Given this list of marker genes ARPC1A, KDM1A, MDM4, FAM204A, TMEM68, COPS7A, USP22, NUP133, MDC1, PTRH2, CSNK1A1, CASP6, XRCC6, GNL2, ZFR, RGMB, TOR1B, CNKSR3 (CNKSR family member 3), MOGS, TESK1, KBTBD4, EXOC5, MOB1B, DDX19B, EFTUD2, GMPPB, VPS50, ADGRE5, SUCO, CYP4A11, ZNF644, C5orf34, CDK6, GNPTG, H2AX, PCYT2, DIABLO, GMDS, IFT140 (NCBI Gene Id 9742), YBX3, GPR89B, DPP7, MED13, MAD2L2, TRIR, RAB3GAP2, FLT3, MIGA1, RBPJ, PRKAR2A, BMPR2, SMIM30, PLBD2 (phospholipase B domain containing 2), EIF4G3, GLRX3, ZNF655, RAP1GDS1, CTDSPL2, ATG5, ZNF565, PDE4DIP, TRIT1 (NCBI Gene Id 54802), C10orf88, FTSJ3, LAMP1, IWS1, DNAJB11, TCF7L2, TLE4, STAU2, RPL13A, RCOR3 (REST corepressor 3), SPMAP1, ACTR10 (NCBI Gene Id 55860), HPGDS, NCOA3, ABI2, ERAP1, YIPF4, SLC39A2, BRMS1L (NCBI Gene Id 84312), RSPRY1, ROCK2, HDAC3, MRPL22, FPR2, PPIH, IFT57, IRAG2, ABCB6, LONRF3, HOOK2, RORA, TMEM70 (NCBI Gene Id 54968), GGNBP2, SMC2, PHTF2, RDH14, C5orf24, HDHD5, B4GALT1, CENPQ, CSGALNACT2, MRPS34, THAP4, SUV39H1, PECR, ZNF322, RAC1, EAF2, CEP135, DTWD2, RNASEH2A, MGA, ANXA7, SLC52A2, XPC, TAF1B, AAK1, CLPX, MANF, RPS25, CUL2, QTRT2, ASNSD1, WDR3, ACD, PLEKHA3, RCN2, PSMD4, BOP1, PHF23, HLA-DRB1, HECA, MAPK1IP1L, EMC2, MRPL38, KCTD10, FAM174A, PRXL2C (peroxiredoxin like 2C), C8orf76, GEMIN5, EMB, CREBRF, ARID4A, NKAPD1, FUCA1, FAM98A, LACTB, CXCR6, CDC27 (cell division cycle 27), UBE3D (NCBI Gene Id 90025), DDX24, GFM1, SPAG4, DNAJC6, BTBD19, FPGT, TMEM179B, ECI1, MARVELD2, EGR3, CIMIP6, SMIM7, PDLIM5, CXCL3, COX17, ATG2A, PTGES2, TRAPPC10, TXNDC5, SEC63, DALRD3, MED19 (mediator complex subunit 19), HOOK3, ELAPOR2, PARG, ORC3, JMJD6, IL1RN, SNX25, INTS11, PSPH, NIPSNAP3A, ELOC, ERG28 (ergosterol biosynthesis 28 homolog), CENPL, COQ7, APOE, PFN1, TTC5, CFAP69, TRAPPC8, QNG1, OXSR1, FGA, ZHX2, COPS4, GPR107, DHX9, here is a description of the gene set: species: Homo sapiens from publication Filén S, Ylikoski E, Tripathi S, West A, Björkman M, Nyström J, Ahlfors H, Coffey E, Rao KV, Rasool O, Lahesmaa R (PMID 20304822) Genes up-regulated in the activated CD4 T cells (48h): control versus IL-12. Human Gene Set: GSE20198_UNTREATED_VS_IL12_TREATED_ACT_CD4_TCELL_UP The aim of this study was to identify genes regulated by IL-12, IL-18 and IFN-alpha during early differentiation of human Th1 cells